The following is a description of a gene set: Binding to a class II myosin, any member of the class of 'conventional' double-headed myosins that includes muscle myosin. studied in species Mus musculus Mouse Gene Set: GOMF_MYOSIN_II_BINDING, and this is the list of marker genes: Gcsam, Llgl1, Llgl2, Stxbp5l, Stxbp5, Shroom4, Gsn, Limch1, Shroom1 (NCBI Gene Id 71774), Nherf1 (NHERF family PDZ scaffold protein 1)